Given this list of marker genes Rps6ka2, Irak1, Uba52rt, Map3k8, Irak2, Ikbkg, Fbxw11, Chuk, Tab1, Mapk11, Tab2, Dusp6, Cul1, Mapkapk2, Ppp2cb, Tab3, Atf1, Ikbkb, Ppp2r1a, Map2k3, Ripk2, Vrk3, Creb1, Rps6ka1, Tnip2, Map2k7, Rps6ka5, Nod1, Ube2v1, Mapk9, Skp1, Ubb (ubiquitin B), Dusp4, Mapk7, Rps27a, Mapk3, Atf2, Mapk1, Mapkapk3, Nod2, Ppp2r1b, Ubc, Map2k4, Rps6ka3 (ribosomal protein S6 kinase polypeptide 3), Map2k6, Mapk8 (mitogen-activated protein kinase 8), Uba52, Traf6, Ube2n, Map3k7, Mapk10, Dusp7, Mapk14, Ppp2r5d, Nfkb1, Ppp2ca, Dusp3 (dual specificity phosphatase 3 (vaccinia virus phosphatase VH1-related)), Jun, Fos, here is a description of the gene set: Mouse Gene Set: REACTOME_INTERLEUKIN_17_SIGNALING studied in species Mus musculus Interleukin-17 signaling